The following is a description of a gene set: studied in species Homo sapiens Genes having at least one occurrence of the motif NAWTTCYNGGAANYN in the regions spanning 4 kb centered on their transcription starting sites. This matches the STAT5A transcription factor binding site V$STAT5A_01 (v7.4 TRANSFAC). Human Gene Set: STAT5A_01, and this is the list of marker genes: MRPL24, BATF3, IRF2BP1 (interferon regulatory factor 2 binding protein 1), PCSK2, FRMD6, GLRA2, ICAM1 (NCBI Gene Id 3383), IRF2, TRIM15, PHOX2B, CSN1S1, LIF, CACNA1D, SYNPO, PAN2, PLAGL1, SDC1, WNT3, NFATC4, MASP2, AP2S1, CISH, VIP, C7, TUT1, EDEM2, COL25A1, TLX2, ATP8A2, CITED4, CCL2, SLC26A9, OLFML1, SDHAF2, NOB1, NUDCD1, SEC24C, PROK1, MAFF, STEAP4, CMTM6, NTF4, MTTP, LIN28A, MIR17HG, FAP, VAX1, APBB1, ELL, ASXL1, ATP5PD, FGA, STC1, PDLIM1 (NCBI Gene Id 9124), IFT80, PURA, SREK1, SOD1, JADE2, PPARGC1B, FLT1, LSAMP, PTCHD4, LINC00656, SEMA6D, ZNF423, PROS1, SMC6, LEP, PLSCR1, CSN3, XRCC1, S100A3, UNC13B, SOCS2, ZNF233, HNRNPR, SLITRK4, VTN, RESF1, LAMA1, MXD1, ECEL1, AGRP, TAL1, SARM1, BET1, GSK3A, RBM14, SCN3B, HJV, ADAMTS9, IFT43, GMPPB, GK, DLX4, TMEM60, SMC4, SLC38A5, PSD (NCBI Gene Id 5662), TSPAN4, NDUFS2, AZI2, YWHAQ, BCLAF1, PHC1, ABCC5, CREM, NCALD, SLCO1B1, TMLHE, SGIP1, TMOD3, NFIL3, HCN4, CPSF7, DGKA (diacylglycerol kinase alpha), ARHGEF39 (Rho guanine nucleotide exchange factor 39), GPR153, MAP4K4, MAP2K3, CPNE1, NRP1, KLF4, PRKAR2B (NCBI Gene Id 5577), SNCB, ZYX, DIS3L, CERT1, DRC7, BBS1, SRPX, KCNN3, PPARD, FOXA3, ING2, ZNF180, TMEM163, PRELID2, AMBN, CHN2, LIX1, RAB11B, CORT, MECP2, BATF, CXCL11, STX19, OLFML3, UBR1, DTX2, WIPF1, SMPD1, KCNJ8, ZNF235, RBFOX1, COQ8B, TNS2, OIT3, HAMP, IFTAP, TRIM46, FOS, CCDC25, SPMIP6, BDNF, CCL5, TSPAN6, PALLD, PHF21B, ENPP2, EGFL6, ITPKC, PCOLCE, IRF4, LIN54, PI4KB, KCNK4, ZNF112, CEP41, CFAP65, CXCR5, CREBRF, SCRG1, GPATCH4, TNFRSF9, DLL4, RRAS (NCBI Gene Id 6237), CSF3, IWS1, ANK3 (NCBI Gene Id 288), MARCHF10 (membrane associated ring-CH-type finger 10), BCL6, HOXA2, LINC00652, IRF1, NR4A2, CTPS1, NR4A3, KLF9, ATP11C, AKR1A1, OGG1, COLQ, ATP2A2, MAPK10, OSM (oncostatin M), MGAT4C, PSMD3, SEPTIN9, ST8SIA1, TNFSF11, TCEA2, NFIA, ADAMTS4, APOLD1, SIGIRR, FBXL9P, NT5C2 (5'-nucleotidase, cytosolic II), HACE1, LAMA2, GRN, PMCH, ETV5, SLC9A1, APBA1, TSHZ2, SERPING1, IKZF4, POU4F1, TMEM100, PVALB, ACY3, IRF9, SYMPK (symplekin scaffold protein), CEBPG (NCBI Gene Id 1054), TMEM74B, NDST1, USP25, GRB10, ATXN7L2, HSF4, ARHGAP36 (Rho GTPase activating protein 36), EIF4E, ZNF532, KRTCAP2, C1QTNF1, NRXN3, TMEM208, RFX4, CYP26A1, TLR7 (toll like receptor 7), RARA, ARF3, LAPTM4B, CD40LG, PRDM1, F9, ADAMTSL3